The following is a description of a gene set: Eukaryotic DNA is associated with histone proteins and organized into a complex nucleoprotein structure called chromatin. This structure decreases the accessibility of DNA but also helps to protect it from damage. Access to DNA is achieved by highly regulated local chromatin decondensation. <br><br>The 'building block' of chromatin is the nucleosome. This contains ~150 bp of DNA wrapped around a histone octamer which consists of two each of the core histones H2A, H2B, H3 and H4 in a 1.65 left-handed superhelical turn.<br><br>Most organisms have multiple genes encoding the major histone proteins. The replication-dependent genes for the five histone proteins are clustered together in the genome in all metazoans. Human replication-dependent histones occur in a large cluster on chromosome 6 termed HIST1, a smaller cluster HIST2 on chromosome 1q21, and a third small cluster HIST3 on chromosome 1q42. Histone genes are named systematically according to their cluster and location within the cluster.<br><br>The 'major' histone genes are expressed primarily during the S phase of the cell cycle and code for the bulk of cellular histones. Histone variants are usually present as single-copy genes that are not restricted in their expression to S phase, contain introns and are often polyadenylated (Old & Woodland 1984). Some variants have significant differences in primary sequence and distinct biophysical characteristics that are thought to alter the properties of nucleosomes. Others localize to specific regions of the genome. Some variants can exchange with pre-existing major histones during development and differentiation, referred to as replacement histones (Kamakaka & Biggins 2005). These variants can become the predominant species in differentiated cells (Pina & Suau 1987, Wunsch et al. 1991). Histone variants may have specialized functions in regulating chromatin dynamics. <br><br>The H2A histone family has the highest sequence divergence and largest number of variants. H2A.Z and H2A.XH2A are considered 'universal variants', found in almost all organisms (Talbert & Henikoff 2010). Variants differ mostly in the C-terminus, including the docking domain, implicated in interactions with the (H3-H4)x2 tetramer within the nucleosome, and in the L1 loop, which is the interaction interface of H2A-H2B dimers (Bonisch & Hake 2012). Canonical H2A proteins are expressed almost exclusively during S-phase. There are several nearly identical variants. No functional specialization of these canonical H2A isoforms has been demonstrated (Bonisch & Hake 2012). Reversible histone modifications such as acetylation and methylation regulate transcription from genomic DNA, defining the 'readability' of genes in specific tissues.<br><br>N.B. Histone literature typically refers to coordinates of the protein after the initiating methionine has been removed; therefore the coordinates of post-translated histone residues described here are frequently +1 when compared with the literature. 2014. Reactome Pathway: Chromatin modifying enzymes part of: Chromatin organization species: Homo sapiens, and this is the list of marker genes: PRMT6, ACTL6B, H2AX, ING5 (inhibitor of growth family member 5), PADI6 (peptidyl arginine deiminase 6), NSD1, SMARCC1, VPS72, PHF2 (NCBI Gene Id 79448), MBD3, H2BC15, MSL1, ING3, HDAC1, KDM1A, KDM5A, H2BC9, H2BC13, H2BC1, KDM4B, DNMT3A, RCOR1, ENY2, MTA2, DMAP1, MCRS1, ARID2, USP22, SUPT7L, SMARCB1, ATF2, NSD3, EP400, H2BC26, KMT5A, PRMT7, EHMT1, ARID4A (NCBI Gene Id 5926), TAF6L, KAT14, SMARCD2 (SWI/SNF related, matrix associated, actin dependent regulator of chromatin, subfamily d, member 2), ASH1L, ZZZ3, H2AC20, KMT5C, MEAF6, H2BC21, WDR77, COPRS, RIOX2, EHMT2, KMT2D, H3C15, H2AC4, MORF4L2, PADI2, UTY, ELP6, MORF4L1 (mortality factor 4 like 1), REST, KDM4A, GATAD2B, H2BC5, MECOM, RUVBL2, RBBP5, KAT6B, TADA3, TAF5L, NCOR1, EZH2, TAF10, KDM2B, ARID1B, PRDM16, TADA2A, PAX3, HCFC1, KAT8, PRDM9 (NCBI Gene Id 56979), KANSL3, ARID5B (NCBI Gene Id 84159), BRPF3, KMT5B, ELP5, SETD7, HMG20B, ACTB, HDAC8, H2AC18, PRMT3, ELP4, KDM4D, KANSL2, SETD6 (SET domain containing 6, protein lysine methyltransferase), NCOA1, SUV39H1, H2AC11, MTA3, KMT2B, KANSL1, HDAC10, SETD3, KDM5B, H2BC3 (NCBI Gene Id 3018), GATAD2A, ACTL6A, RUVBL1, TAF9, SETD2, H2BC11, BRD8 (NCBI Gene Id 10902), KMT2A, MSL2, H2AC6, NFKB2, PADI4, YEATS2, ASH2L, H2AB1, TAF12, SMARCD1, SUDS3, SAP30L, EP300, GPS2, SAP130, H2AC7, JADE3, EED, ELP1, CREBBP, PADI3, BRMS1, HAT1, BRD1, SAP30 (Sin3A associated protein 30), SMYD3, SUPT3H, NFKB1, SUPT20H, CHD4, KDM6A, KDM3A, SUZ12, SMARCC2, PHF8, JADE2, H2BC17, TBL1X, H2AC25, HDAC3 (histone deacetylase 3), ATXN7, KAT2A, SMARCD3, SMARCA2, PADI1, YEATS4, TRRAP, CCND1, ELP2, RELA, KAT7, PRMT1, AEBP2, SETDB1, KDM5D, BRPF1, DPY30, H2AJ, SETDB2, JAK2, SGF29, KDM5C, ARID4B, RBBP4, NCOR2, NCOA2, SETD1A, ARID1A, KAT5, MRGBP, CDK4, ING4, SAP18, SMYD2, PHF20, H2AC21, DR1, KDM3B, KDM7A, JADE1, MTA1, H2AC1, CARM1, H2AC12, H2BC4, KDM4C, PRMT5, ATF7IP, SMARCA4, EPC1, H3C1, NSD2, H2AZ2, SMARCE1, CHD3, KDM1B, ELP3, TADA1, BRWD1, CLOCK, H2AC14, PBRM1, RBBP7, MSL3 (NCBI Gene Id 25867), H2BC18, TADA2B, ATXN7L3, H2BC14, DOT1L, PHF21A, SETD1B, KMT2C, OGT, KDM2A, TBL1XR1, H4C1 (NCBI Gene Id 8359), WDR5, KAT2B, KAT6A, HDAC2, SUV39H2, KDM6B, JMJD6, MBIP, RPS2, H2BC12 (NCBI Gene Id 85236)